The following is a description of a gene set: studied in species Homo sapiens Human Gene Set: chr9q32, and this is the list of marker genes: INIP, FAM225B, ALAD, TNFSF15, MUPP, RNF183, RNA5SP295, KIF12, PTBP3, SLC46A2, KIAA1958, BSPRY, PRPF4, FAM225A, SUSD1, ORM1, WDR31, RPL32P22, HSDL2-AS1, ATP6V1G1, TEX48 (testis expressed 48), TEX53, RN7SL57P, ZNF618, ZFP37, SNX30-DT, ORM2 (NCBI Gene Id 5005), AKNA, HDHD3, RNU6-855P, DELEC1, WHRN (NCBI Gene Id 8016), C14orf119P1, CDC26, FKBP15, HSDL2, RGS3, SLC46A2-AS1, COL27A1, SNX30, RPL29P20, HSPE1P28, SLC31A2, POLE3, RN7SL430P, MIR455, C9orf43, TMEM268, AMBP, ZNF883, SLC31A1